Given this list of marker genes OCRL, IER3IP1, SLC4A2, RECQL4, AGXT, ALPL, HACE1, TCIRG1, TP53, LTBP1, GBA1, TYROBP, EFEMP2 (EGF containing fibulin extracellular matrix protein 2), ATP7B, TNFRSF11A, CCND1, PTH1R, HNRNPA2B1 (heterogeneous nuclear ribonucleoprotein A2/B1), MYCN, SCARB2, PHOX2B, SLC34A3, SLC7A7, B2M, ALK, B3GALT6, SLC34A1, AGA (NCBI Gene Id 175), CBL, SMPD1, ATL1, ATL3 (NCBI Gene Id 283241), HNRNPA1, UROS, RB1, IDH1, CHEK2, SRSF2, SLC4A1, SPTLC1 (serine palmitoyltransferase long chain base subunit 1), TREM2, PLOD3, IDH2, ASXL1, VCP, MET, LIFR, GNAS, SPTLC2 (NCBI Gene Id 9517), LIN28B, LRP5, CTC1, BANF1, GK, NOTCH2, GNPTAB, LMO1, FBLN5, MTAP, RUNX1, TET2, here is a description of the gene set: species: Homo sapiens A pathologic fracture occurs when a bone breaks in an area that is weakened secondarily to another disease process such as tumor, infection, and certain inherited bone disorders. A pathologic fracture can occur without a degree of trauma required to cause fracture in healthy bone. Human Gene Set: HP_PATHOLOGIC_FRACTURE Pathologic fracture